The following is a description of a gene set: Abnormality of temperature regulation Human Gene Set: HP_ABNORMALITY_OF_TEMPERATURE_REGULATION species: Homo sapiens An abnormality of temperature homeostasis., and this is the list of marker genes: NALCN, CTRC, MT-CO1, NLRP1, UQCRH, RNU4ATAC, GLI2, AQP2, MECP2, F5, CCR1, PLCE1, KDF1, ITPR2, TBCK, PTS (NCBI Gene Id 5805), FCGR3B, ADA2, CLCF1, BCAP31, MTMR14, NUP37, CD70, LSM11, BLK, IRF2BP2, MT-ND1, CYP11B2, PSENEN, TRAF3IP2, C1QB, UBE2L3, ARL3, NGLY1, PSTPIP1, PIK3CG, TRAF3, CYP21A2, IRF1, BTNL2, PSMB4, SH2B3 (NCBI Gene Id 10019), DPP9, LIG4, MIF, DAAM2, LMNB1, MT-CO3, NABP1, BRCA2, CHEK2, UNC93B1, VPS11, PSMG2, MEFV, CRLF1, ITK, UNC13D, FOCAD, MYF6, SYK, PI4K2A, ITGAM, DDB2, NUP93, LYN, C4B, AVP, CCND1, MCM10, PWAR1, LAMB3, RIPK1 (NCBI Gene Id 8737), LPIN1, JAZF1, NUMA1, TSHB (thyroid stimulating hormone subunit beta), SUCLG1, ADAR, HACE1, TREX1, NCF4, GATA2, SNORD116-1, PHOX2B (NCBI Gene Id 8929), SHQ1, RARA, SLC4A1, COQ8B, SLC39A7, UBA1, NAXD, MAP2K2, AP1S3, ETS1, XPC, NAB2, HNRNPK, MT-CO2, STIM1, CHRNA1, LAMA3, CPOX, CFHR3, IFIH1, PLA2G6, BANK1, DLL1 (NCBI Gene Id 28514), TRAF6, SPTA1, COA6, IGLL1, LDHA, PLCH1, LIPA, ERCC3, MADD, CLPB, COL1A1, MT-TL1, OTC, NFU1, ANKFY1, PSAP, FCGR2B, HEPHL1, CLCN7, TBC1D8B, CLDN10, MT-ATP6, TNIP1, CFTR, MCTS1, SCN4A, H19, PSMB10, TBX3, CD3D, TNFRSF1A, STAT1, MAGI2, ARHGAP24, PDCD1, PTPRC, SCN10A, OFD1, IL17F, IRF8, TLR4, SCN5A, IYD, CD244, GYPC, ROS1, PRNP, SPTBN1, GPR35, TNFAIP3, TCF4, NKX2-1, SLC5A5, PTPN2, NUP85, IGHG1, ARHGDIA, PEX6, PTPN22, TICAM1, DNM2, RNF168, STIL, PRKCD, CD79A, FOXH1, SLC12A1, PAX2, MVK, ACTN4, SCO2, PMM2, TRIP13, IL10, SIX3, ACADSB, KRT5, TCIRG1, POFUT1, DGUOK, TPO (NCBI Gene Id 7173), CFHR1, SPI1, CHRNG, ASAH1, LHX3, CDON, ABCC2, LHX4, ALPL, ALG11, DNASE1, RNASEH2A, CACNA1S, NODAL, ZFHX2, HLA-DPA1, RAG2, OTULIN, HMGCL, ABCC6, TBK1, IL23R, MTHFS, SAT1, MRPS7, TCF3, PTPRO, TH, EIF2B1, FIP1L1, MST1, ERCC8 (NCBI Gene Id 2075), ZFYVE19, ERCC2, SLC34A2, IGHM, MT-TW, LIFR, NLRC4, MT-ND2 (NCBI Gene Id 4536), ENPP1, MMACHC, ASXL1, NOD2, LIN28B (lin-28 homolog B), FBP1, COL4A3, CYBB, TSPOAP1 (TSPO associated protein 1), STAT6, ELANE, IL12B, HAVCR2, ATP2A1, MT-ND5, BRAT1, MBTPS2, ZMYM3, SMARCAL1, CLEC7A, RYR1, ADA, ANKRD55, NRAS, POGLUT1, PSMB9, PRF1, IL6, TLR3, IL17RA, RNASEH2C, PSMB8, NLRP12, TG, HBB, LBX1, LBR, C4A, TMEM165, TRPC6, ATP13A2, DUOX2, HERC2, PRKAR1A, EDA, CRIPTO, KLRC4, NPM1, HSPG2, CHD7, KRT18, FAH, MPL, MKRN3, LAMC2, CD27, SCN9A, SLC5A1, POU1F1, XIAP, SLC31A1, KRT14, TNFRSF11B, BRAF (NCBI Gene Id 673), DIS3L2, NUP107, TP53, IL36RN, IL2RB, MT-CYB, PXK, WT1, PRSS1, POMP, SLC25A19, MT-TS2, SCNN1B, COG7, RB1, NGF, MICOS13, IBA57, SLC22A4, DUOXA2, ERCC5, NCF1, WAS, IL2RG, CACNA1A, STAT4, SCN11A, CALR, LMO1 (NCBI Gene Id 4004), IFNG (interferon gamma), CYBC1, TBL1XR1, SHANK3, NCF2, TLR7, HESX1, SH2D1A, MYD88, SLC29A3, NECTIN4, CRELD1, BCL2, QDPR, SCYL1, GPC3 (glypican 3), MT-ND6, CD79B, ALDOA, TRNT1, KIT, CFH, NFKBIA, HLA-B (NCBI Gene Id 730410), MAGEL2, OBSCN, BIN1, GAA, ALOXE3 (NCBI Gene Id 64048, arachidonate epidermal lipoxygenase 3), MYO1H, ALPK1, P4HA2, MYH3, IKZF1, MT-TK, NPHS1, ANK1, TET2, GAPVD1, JAK2, ABCA12, PTPN6, LYST, COQ9, LACC1, SLC18A2, PML, RUNX1, CR2, CACNA1C, KIF1B, TSPYL1, SRSF2, IFNGR1, STAT5B, BIRC3, MAP2K1, IRAK4 (interleukin 1 receptor associated kinase 4), C2orf69, ELP1, CRLS1, MT-TF, SCNN1A, NTRK1, NPAP1 (NCBI Gene Id 23742), MT-TH, RNF31, EIF2AK3, EDARADD, BCL10, HLA-DPB1, GABRA2 (gamma-aminobutyric acid type A receptor subunit alpha2), TNFRSF1B, STAG2, SAMHD1, CBLB, GFI1, ORAI1, RBCK1, RAB27A (RAB27A, member RAS oncogene family), ZNF699, IL6R, CD28, MYCN, IL17RC (interleukin 17 receptor C), H4C5 (H4 clustered histone 5), STAT2, APOL1, CD2AP, TSC1, MLX, KIAA0319L, SLC19A1, AVPR2, ERAP1, DCLRE1C, RAG1, PKHD1, TSC2, IL1R1, FGF8, TGIF1, SLC12A3, PTCH1 (patched 1), SPR, REL, MYO1E, BRCA1, SLC41A1, DST, STXBP2, PIK3R1, UBAC2, TRAPPC9, DISP1, ATP7A, EDAR, ANLN, PAX8, UBE3A, NFKBIL1, STAT3 (NCBI Gene Id 6774), CIITA, PMP22, SPINK1, IVD, KLHL7, CEBPE, GALC (galactosylceramidase), NUP160, SMC1A, HMBS, OCA2, STING1, EMP2 (epithelial membrane protein 2), ANKH, ABL1, ZBTB16, ACAT1, ERCC6, STAC3, DDC, IL12A, STX11, MT-TQ (mitochondrially encoded tRNA-Gln (CAA/G)), IL12A-AS1, SNX10, NPHS2, BCL6, PGM1, CHRND, RMRP, DBH, ATM, ATP1A2, BACH2, PRSS2, RNU7-1, FGFR1, PRTN3, G6PD, POU6F2, MT-TV, CRB2, SLC19A3, CD247, EPB41, C3 (complement component 3), NUP133, LPIN2, IL7R, SRP19, STK4, CD3E, CYBA, RANBP2, XPA, NAGS, NLRP3, SEMA4D, DNASE2, ACADVL, SLC35C1, PROP1, GCH1, LCK, FOXP1, WIPF1, GLA, CLCN6, CASK, IL2RA, INF2, LRRC8A, RNASEH2B, ADAMTS13, CPT2 (NCBI Gene Id 1376), IRAK1, PWRN1, NUP205, EPB42, SHARPIN, COG6, KCNJ1, UQCRFS1, TNFSF4, BTK, TSHR, SNORD115-1, HLA-DRB1, ATP5F1B, ELF4, WDR1, FAS, ZIC2, ALK, SHH, HTR1A, MT-ND4, IRF5, REST, ATXN3, NDUFA2, ZNFX1, SLC52A1, SLC25A20, AK2, GAS1, BLNK, TNFSF11, ERCC4, PTPN3, DOCK2, MALT1, SPP1, CTLA4, TRANK1, DEF6, SPTB, MT-ND3, POLR3A, BCOR, P4HTM, BCR, SCNN1G, TRIM28, IRF4